Given this list of marker genes MMAB (NCBI Gene Id 89909), here is a description of the gene set: part of: Defects in cobalamin (B12) metabolism Reactome Pathway: Defective MMAB causes MMA, cblB type Defects in MMAB cause methylmalonic aciduria type cblB (cblB aka methylmalonic aciduria type B or vitamin B12 responsive methylmalonicaciduria of cblB complementation type; MIM:251110). Affected individuals have methylmalonic aciduria and episodes of metabolic ketoacidosis, despite a functional methylmalonyl CoA mutase. In severe cases, newborns become severely acidotic and may die if acidosis is not treated promptly. studied in species Homo sapiens